The following is a description of a gene set: studied in species Homo sapiens Human Gene Set: MENON_FETAL_KIDNEY_5_PROXIMAL_TUBULE_CELLS from publication Menon R, Otto EA, Kokoruda A, Zhou J, Zhang Z, Yoon E, Chen YC, Troyanskaya O, Spence JR, Kretzler M, Cebrián C (PMID 30166318), and this is the list of marker genes: ETFB, HOOK1, TXN, VCAN, ODC1, SPATS2L, IGFBP7, DAB2, PCBP2, CD164, PTGR1, JAG1, LAPTM4A, GLYATL1, DBI, CYBA (cytochrome b-245 alpha chain), GNG11, HSPE1, ATP6V1F, DYNLRB1, ARID5B (AT-rich interaction domain 5B), SLC27A2, SELENOP, SMS, TPT1P9, HADHA, LAMTOR5, FTH1, MRPL32, RAB3IP, ITM2B, TPT1, CUBN, RPL10P9, RPS4Y1, NIPSNAP1, RPS2P5, ID4, PSMA2, CALM3, SNHG29, KCNJ15, APOE, TNFSF10, ATXN7L3B, S100A10 (S100 calcium binding protein A10), AKR1A1, UGCG, TSPAN12, FLRT3, CTSB, QPRT, ATP5PD, ACAA2, CD24, TMBIM6, RPS7, AFP, SPEF2, CITED2, SNHG8, DSEL, ID2, APOM, ATP5IF1, AIG1, DNPH1, OCIAD2, NHERF1, CALM1, RPL14P1, RTN4, PPFIBP1, SMIM24 (small integral membrane protein 24), SLC3A1, CARMIL1, HSPD1, EPHA7, SYNE2, MYO6, MPC2, ANXA4, DPP4, MSRB1, CCDC198, CYB5A, DCDC2, CLU, RNF181, SPINT2, TUBB4B, FARP1, ATP6V1G1, FTLP3, LRP2, EMX2, CDH6, FTL, GPC3, ALDH6A1, NPC2, SYAP1, ID1, SPP1, NDUFC1, RIDA, MDH1, ATP5PF, PTTG1IP, C11orf54, PDZK1, MTCO1P12